The following is a description of a gene set: Prominent antihelix The presence of an abnormally prominent antihelix. studied in species Homo sapiens Human Gene Set: HP_PROMINENT_ANTIHELIX, and this is the list of marker genes: RECQL4, KAT6A, MGAT2 (alpha-1,6-mannosyl-glycoprotein 2-beta-N-acetylglucosaminyltransferase), SLC16A2, FIG4, GLI2 (NCBI Gene Id 50806), PGAP1, WAC, RAB11B, BICRA, EVC, NR2F1, EVC2, TOR1A, RBM10, AP4E1